The following is a description of a gene set: Endosomal Sorting Complex Required For Transport (ESCRT) studied in species Homo sapiens Human Gene Set: REACTOME_ENDOSOMAL_SORTING_COMPLEX_REQUIRED_FOR_TRANSPORT_ESCRT, and this is the list of marker genes: VPS36, VPS37D, CHMP4B (charged multivesicular body protein 4B), VPS4A, CHMP4C, MVB12B, UBA52, STAM2, CHMP3, CHMP2B, UBB, VTA1, VPS37A, CHMP4A, MVB12A, UBC, HGS, CHMP5, RPS27A, SNF8, CHMP2A, VPS37C, TSG101, VPS4B, VPS37B, UBAP1, CHMP6, STAM, VPS28, CHMP7, VPS25